Given this list of marker genes ANXA8L1, TGM2, NMB, GNG4, RASSF2, RIMS2, EFNB2, FOS, NNMT, IGFBP6, ISG20, CXCL12, ADORA1, KCNG1, PTX3, E2F5, LHX2, CTSH, IGFBP2, ANPEP, HOXB5, MDK, GAGE12F, PCDH7 (protocadherin 7), IGSF3, EPB41L3, MEST, PTPRN, here is a description of the gene set: Human Gene Set: DACOSTA_ERCC3_ALLELE_XPCS_VS_TTD_UP species: Homo sapiens Xeroderma pigmentosum (XP) and trichothiodystrophy (TTD) syndromes are characterized by deficiency in nucleotide excision repair pathway, but with distinguished clinical manifestations. While XP patients exhibit a high frequency of skin cancer, TTD patients are not cancer prone. The relation between lack of DNA repair and their clinical manifestations was investigated through analysis of the transcriptional profile of 12,600 transcripts in two isogenic cell lines with different capabilities of DNA repair. These cell lines result from a stable transfection of the XPB-TTD allele into XP complementation group B fibroblasts, from an XP patient who also have clinical abnormalities corresponding to Cockayne's syndrome (CS). The microarray assays performed under normal growth conditions showed the expression of distinct groups of genes in each cell line. The UVC-transcription modulation of these cells revealed the changes in 869 transcripts. Some of these transcripts had similar modulation pattern in both cells, although with eventually different time patterns for induction or repression. However, some different 'UVC signature' for each cell line was also found, that is, transcripts that were specifically UV regulated depending on the DNA repair status of the cell. These results provide a detailed portrait of expression profiles that may potentially unravel the causes of the different phenotypes of XP/CS and TTD patients. Genes up-regulated in fibroblasts expressing different mutant forms of ERCC3: XP/CS (xeroderma pigmentosum (XP) and Cockraine's syndrome (CS)) vs TTD (trichothiodystrophy). from publication da Costa RM, Riou L, Paquola A, Menck CF, Sarasin A (PMID 15608684)